The following is a description of a gene set: Human Gene Set: MIR4712_5P Genes predicted to be targets of miRBase v22 microRNA hsa-miR-4712-5p in miRDB v6.0 with MirTarget v4 prediction scores > 80 (high confidence targets). species: Homo sapiens from publication Chen Y, Wang X (PMID 31504780), and this is the list of marker genes: APELA, GCSAML, EML4, RRAGB, HERC3, CCDC85A, ZFP90, ADD3, ADGRV1, STK38L, CPEB3, TLNRD1, CNTN4, CCDC60, ZNF99, BAZ1A, OGT, SP4, CCND2, DSE (NCBI Gene Id 29940), MYO6, ZNF117, CABLES1, PPP4R2, TMEM178A, TFCP2, ELL2, CPEB2, RAD23B, BTG1, TMEM38B, ZNF138, PLXDC2, FLI1, CKS1B, PPP3CA, ZNF107, GMFB, RCHY1, NUDCD1, DHTKD1, KAT2B, KCNMB2, NETO1, ZC3H12C, NTRK2, TMEM132C, KIF13A, STK17A, ZDHHC11, ZNF208, MARK1, MYH10, PAFAH1B2, SLC17A6, AKIRIN2, GTDC1, ZHX2, XAF1, DIAPH3, SMARCC1, CDKL4, RAC2, PDCD2, ZNF764, PTPN12, IPMK, AMIGO2, ZCCHC2 (zinc finger CCHC-type containing 2), TANC2, MATN2, CNOT6L, HSPA5, SORT1, MBTD1, GOLGA7, NAP1L1, MMAA, ZNF765, RBM46, PBX1, MNX1, SAMD3, MAP3K1, ARHGAP12, SIRT7, BLTP3A, TARS1, MAOA, UBR3, ZNF676, AQP4, TLCD3A, DLST, BICC1 (BicC family RNA binding protein 1), ZFAND3 (NCBI Gene Id 60685), NAA15, IKZF2 (NCBI Gene Id 51173), TDP1